The following is a description of a gene set: species: Homo sapiens Glycosyltransferase-like protein LARGE (MIM:603590) is a bifunctional glycosyltransferase with both xylosyltransferase and beta-1,3-glucuronyltransferase activities involved in the biosynthesis of a phosphorylated O-mannosyl trisaccharide, a structure present in alpha-dystroglycan (DAG1; MIM:128239) which plays a key role in skeletal muscle function and regeneration. LARGE contains two substrate-specific GT-domains and belongs to the CAZy glycosyltransferase families GT8 and GT49. Defects in LARGE result in hypoglycosylation of DAG1 and cause several congenital muscular dystrophies (CMDs). Muscular dystrophy-dystroglycanopathy congenital with brain and eye anomalies A6 (MDDGA6; MIM:613154) is associated with brain anomalies, eye malformations, profound mental retardation, and death usually in the first years of life. Muscular dystrophy-dystroglycanopathy congenital with mental retardation B6 (MDDGB6; MIM:608840) is associated with profound mental retardation, white matter changes and structural brain abnormalities. part of: Diseases associated with O-glycosylation of proteins Reactome Pathway: Defective LARGE causes MDDGA6 and MDDGB6, and this is the list of marker genes: LARGE1, B4GAT1